The following is a description of a gene set: from publication de la Serna IL, Ohkawa Y, Berkes CA, Bergstrom DA, Dacwag CS, Tapscott SJ, Imbalzano AN (PMID 15870273) Genes down-regulated in NIH 3T3 cells (fibroblasts) 24 h after inducing MyoD differentiation program. The activation of muscle-specific gene expression requires the coordinated action of muscle regulatory proteins and chromatin-remodeling enzymes. Microarray analysis performed in the presence or absence of a dominant-negative BRG1 ATPase demonstrated that approximately one-third of MyoD-induced genes were highly dependent on SWI/SNF enzymes. To understand the mechanism of activation, we performed chromatin immunoprecipitations analyzing the myogenin promoter. We found that H4 hyperacetylation preceded Brg1 binding in a MyoD-dependent manner but that MyoD binding occurred subsequent to H4 modification and Brg1 interaction. In the absence of functional SWI/SNF enzymes, muscle regulatory proteins did not bind to the myogenin promoter, thereby providing evidence for SWI/SNF-dependent activator binding. We observed that the homeodomain factor Pbx1, which cooperates with MyoD to stimulate myogenin expression, is constitutively bound to the myogenin promoter in a SWI/SNF-independent manner, suggesting a two-step mechanism in which MyoD initially interacts indirectly with the myogenin promoter and attracts chromatin-remodeling enzymes, which then facilitate direct binding by MyoD and other regulatory proteins. Mouse Gene Set: DELASERNA_MYOD_TARGETS_DN species: Mus musculus, and this is the list of marker genes: Zc3h11a, Cenpm, Dpysl2, Mgst1, Hmgb3, Ttyh3, Cxcl12, Stxbp5, Stard4, Ifitm1, Baiap2 (NCBI Gene Id 97767), Thbd, Cyb5a (NCBI Gene Id 66846), Erbin, Emilin2, Tcf7l1, Pde4b, Zfp777, Ddit3, Adgra2, Postn, Cd47, Rbpms (NCBI Gene Id 80458), Col11a1, Tgfbi, Tpr, Capn6, S1pr3, Gapt, Synpo, Arl14ep, Ms4a4c, Pten, Actl6b, Plp2, Zmynd8, Serpinb9, Rab24, Fnbp4, Prdx4, Vasn, Tut4, Ddx28, Slc5a3, Klf6, Basp1, Itpr2, Mpp7, Gbp2, Pole2, Ccdc24, Slit2, Mmp2, Atp6v0c, Cd34, Sdc2, Fzd1